Given this list of marker genes CXCL10, IL13RA2, INHBA, GCH1, LIF, HSD11B1, SLC39A8, SAT1, RNF128, B3GNT5, OSGIN2, C2CD4B, MIR23AHG, CREB5, SOD2, IFNE, MT1G, DUSP2, MMP1, NAMPTP1, NFKBIZ, CD69, MMP3 (NCBI Gene Id 4314), PTGS2, ATP6V1C1, SLC16A6P1 (SLC16A6 pseudogene 1), GPR68, BIRC3, AHR, SRSF12, STC1, ZSWIM8, IL1A, GADD45G, IL33, CXCL8 (C-X-C motif chemokine ligand 8), MT1X, PLEK2, IRAK3, MT1H, LRRC8B, POU2F2, G0S2, TESC, TCIM, PRR7-AS1, MT1E, MCTP2, LAMB3, SLC7A11, PTGES, TNFSF15, DNAJB4, PHEX, CXCL1, ZC3H12C, PLA2G4A, PTGFR, PPP4R3B, SLC6A15, RELB, IL1B, CXCL2, C9orf72, MT1B, SLC16A6, CXCL5, TUT7, FGF2, NAMPT, EPB41L4B, DUSP5, CXCL3, TNFAIP3, SLC39A14, MCTP1, POPDC3, MMP10, TSLP, KYNU, SERPINB2, RGS9, GCLM, BCL2A1, here is a description of the gene set: Genes significantly (FDR < 10%) up-regulated in IMR-90 cells (fibroblast) in response to bystander irradiation. Human Gene Set: GHANDHI_BYSTANDER_IRRADIATION_UP Background: The existence of a radiation bystander effect, in which non-irradiated cells respond to signals from irradiated cells, is now well established. It raises concerns for the interpretation of risks arising from exposure to low doses of ionizing radiation. However, the regulatory mechanisms involved in the bystander response have not been well elucidated. To provide insight into the signaling pathways responding in bystanders, we have measured global gene expression four hours after bystander and direct alpha particle exposure of primary human lung fibroblasts. Results: Although common p53-regulated radiation response genes like CDKN1A were expressed at elevated levels in the directly exposed cultures, they showed little or no change in the bystanders. In contrast, genes regulated by NF_B, such as PTGS2 (cyclooxygenase-2), IL8 and BCL2A1, responded nearly identically in bystander and irradiated cells. This trend was substantiated by gene ontology and pathway analyses of the microarray data, which suggest that bystander cells mount a full NF_B response, but a muted or partial p53 response. In time-course analyses, quantitative real-time PCR measurements of CDKN1A showed the expected 4-hour peak of expression in irradiated but not bystander cells. In contrast, PTGS2, IL8 and BCL2A1 responded with two waves of expression in both bystander and directly irradiated cells, one peaking at half an hour and the other between four and six hours after irradiation. Conclusion: Two major transcriptional hubs that regulate the direct response to ionizing radiation are also implicated in regulation of the bystander response, but to dramatically different degrees. While activation of the p53 response pathway is minimal in bystander cells, the NF_B response is virtually identical in irradiated and bystander cells. This alteration in the balance of signaling is likely to lead to different outcomes in irradiated cells and their bystanders, perhaps leading to greater survival of bystanders and increased risk from any long-term damage they have sustained. species: Homo sapiens from publication Ghandhi SA, Yaghoubian B, Amundson SA (PMID 19108712)